The following is a description of a gene set: studied in species Homo sapiens A protein complex which is capable of endodeoxyribonuclease activity. Human Gene Set: GOCC_ENDODEOXYRIBONUCLEASE_COMPLEX, and this is the list of marker genes: EME1, SLX4, RAG1, MUS81 (MUS81 structure-specific endonuclease subunit), EME2 (NCBI Gene Id 390668)